The following is a description of a gene set: Human Gene Set: GOBP_REGULATION_OF_PROTEIN_LOCALIZATION_TO_ENDOSOME studied in species Homo sapiens Any process that modulates the frequency, rate or extent of protein localization to endosome., and this is the list of marker genes: DTX3L, EGF, EZR, NF2, ROCK2, VEGFA, MSN, MGAT3, ABHD17A, SORL1, RDX, ANKRD13A, ABHD17C, ABHD17B